Given this list of marker genes Hdac8, Hdac2, Mef2c, Abcb1a, Gfer, Ezh2, Cdkn1b, Slc9a1, Scn3a, Mir208b, Trp53, Pla2g4a, Rpl23, Crip1, Pla2g4f, Star, Mdm2, here is a description of the gene set: Any process that results in a change in state or activity of a cell (in terms of movement, secretion, enzyme production, gene expression, etc.) as a result of an antibiotic stimulus. An antibiotic is a chemical substance produced by a microorganism which has the capacity to inhibit the growth of or to kill other microorganisms. studied in species Mus musculus Mouse Gene Set: GOBP_CELLULAR_RESPONSE_TO_ANTIBIOTIC